The following is a description of a gene set: species: Homo sapiens An isopeptidase activity that cleaves ubiquitin or ubiquitin-like proteins (ULP; e.g. ATG8, ISG15, NEDD8, SUMO) from target proteins. Human Gene Set: GOMF_UBIQUITIN_LIKE_PROTEIN_PEPTIDASE_ACTIVITY, and this is the list of marker genes: USP18, UFSP1, USP28, TANK, UCHL1, USP49, ZRANB1, PSMD7 (proteasome 26S subunit, non-ATPase 7), USP20, OTUD1, USP54, ZC3H12A, USP12, HINT1, USP16, USP31, USP39, USP7, USP17L6P, OTUD7B, USP50, USP33, USP17L21, MINDY4 (MINDY lysine 48 deubiquitinase 4), USP25, SENP7, USP17L8, BRCC3, SENP3, OTUB2, USP9Y, PSMD14, OTUD5, USP17L15, USP17L4, EIF3H, ATXN3L, USP17L1, OTUD4, USP24, USP17L18, MPND, USP17L13, WDR48, COPS5, JOSD1, USP17L11, DESI1, SENP1, OTULINL, USP26 (ubiquitin specific peptidase 26, NCBI Gene Id 83844), MINDY1, USP37, VCP, USP51, USP47, USP42, USP17L17 (ubiquitin specific peptidase 17 like family member 17), USP17L2, USP27X, USP1, OTUD6B, USP14, USP34, STAMBP, USP29, OTUB1, EIF3F, USP17L23, USP19, SENP8, MINDY4B, ATXN3, OTUD6A, USP4, USP21, UFD1, TIFAB, USP10, USP6, USP46, COPS6, UCHL3, MINDY2, USP15, DESI2, USP17L7 (ubiquitin specific peptidase 17 like family member 7), STAMBPL1, USP17L10, USP44, JOSD2, MINDY3, CYLD, USP48, COPS4, USP17L3 (ubiquitin specific peptidase 17 like family member 3), PRPF8, USP17L24, USP30, USP40, SENP2, MYSM1, DMWD, USP17L20, USP32, SENP5, USP43, USP53, USPL1, USP2, BAP1, USP9X, USP13, USP8, ALG13, USP17L12, USP5, VCPIP1, UCHL5, USP11, USP38, ZUP1, OTUD7A, SENP6, TGFB1, USP22, YOD1, USP45, TNFAIP3, WDR20, USP36, OTULIN (OTU deubiquitinase with linear linkage specificity), PAN2, OTUD3, USP3, USP17L19, USP17L5, UFSP2, USP35, USP17L22